Given this list of marker genes SLC12A1, BSND, KCNJ1, CLCNKA, CLCNKB (NCBI Gene Id 1188), here is a description of the gene set: Human Gene Set: HP_HYPERCHLORIDURIA studied in species Homo sapiens An increased concentration of chloride in the urine. Hyperchloriduria